The following is a description of a gene set: Human Gene Set: GSE4142_NAIVE_VS_MEMORY_BCELL_DN In order to better understand the factors that regulate B cell differentiation upon exposure to antigen, we compares global gene expression profiles from naive B cells with antigen-specific plasma, germinal center, and memory B cells after immunization with the T-dependent antigen, NP-CGG. The memory B cell-enriched transcripts were then compared with memory T cell-enriched and hematopoietic stem cell-enriched transcripts in order to generate a transcriptional profile of self-renewal within the hematopoietic system. from publication Luckey CJ, Bhattacharya D, Goldrath AW, Weissman IL, Benoist C, Mathis D (PMID 16492737) species: Homo sapiens Genes down-regulated in B lymphocytes: naïve versus memory., and this is the list of marker genes: ALOX15B, ACOT8, OTOA, CDCP1, GLUL, CCT3, BARX1, CLPS, TRAPPC6B, ASIC1, CTTNBP2, GLB1L, CFAP299, MYH7, PDE3B, HSD11B2, EYA1, SLCO2B1, HPN, CD99L2, BTG4, TTYH1, DLX3, TNFRSF21, EPHA5, SMIM1, RRH, NDUFS6, COQ4, NT5DC3 (5'-nucleotidase domain containing 3), ADAMTS8 (NCBI Gene Id 11095), ATP2A2, OAZ1, CENPH, ATXN10, SLC36A1, LEMD1, LELP1, C3orf33, MZB1, SMOC1, BOLA3, SERPINA1, DNAJC5B, DNAJC6, STRA8, FABP2, TSPAN18, ANGEL1, POU5F1, LRRC1, ERF, ZNF658 (zinc finger protein 658), C1orf52, KRT84, EFNB2, FAM163A, TPM3, PNMA3 (NCBI Gene Id 91916), COL5A1, KRTAP17-1, DYDC2, HBA2, AATK, DACT3, PSD3, TRPA1, CDC25A, SNX22, GFM1, MEST, MORN2, THOC6, EBF4, RPL3L, MXRA8, JMJD8, TMEM190, USP13, SIX3, NNMT, ALG3, VIPR2, CYP2E1, TFF2, TAC3, IL18BP, TNFRSF14 (NCBI Gene Id 93208), CXCL13, PTDSS1, ADCY5, HAPLN3, TULP2, APEX1, DPEP3, KLB, IGLL1, PNMT, DMTN, TLE2, SLC34A3, AQP7, DEFB119, TEX19, TMIE, CLCC1, MC3R, NDUFAF4, TPGS2 (tubulin polyglutamylase complex subunit 2), SLC22A12, TRIM6, AMPD2, ZNF474, STK4, RPN1, TLX3, IBSP, KPNA7, NAT8, TRMT44, SLC22A17, CRCP, PRR16, CCDC138, HOXA7, TIGAR (NCBI Gene Id 57199), ASB18, SOHLH2, MOS, TSHZ2, C2orf72, EFCAB7, SLC25A41, RNF183, MARCHF4, SLC35B1 (solute carrier family 35 member B1), MROH3P, VCAM1, PTGDR2, XPO7, POMP, GNAT2, CRYBB2, YTHDC1 (NCBI Gene Id 91746), CFH, HOXA9, LTB4R2, DPF3, NMI, C21orf58, ZSCAN5B, KCNK10, GSTM4, KRT75, WNT9B (Wnt family member 9B), GPR88, FAM162B, COQ2, OSR1, PROCR, METTL13, ASPA, C5orf46, UPK1B, ELN, POLR2F, RRN3, MDH2, LAMTOR1 (NCBI Gene Id 55004), SLC24A2, NRG1, DRC12, NDUFB9, VRK1 (VRK serine/threonine kinase 1), GAS8, F2, DNAJC22, PRKRIP1, U2AF1 (U2 small nuclear RNA auxiliary factor 1), HACD3, TMEM161A, GPANK1, VPS33B, PRRT4, RPS16, FAM170B, C11orf97, LHX5, ALDOAP2, FTCD, CLGN, AADAC, FBRSL1, CRPPA (NCBI Gene Id 730683), KCNK3, ARSG, RFX2, KRTAP3-1, TMEM132A, RPL13